The following is a description of a gene set: studied in species Mus musculus Radiotherapy is widely used to treat human cancer. Patients locally recurring after radiotherapy, however, have increased risk of metastatic progression and poor prognosis. The clinical management of postradiation recurrences remains an unresolved issue. Tumors growing in preirradiated tissues have an increased fraction of hypoxic cells and are more metastatic, a condition known as tumor bed effect. The transcription factor hypoxia inducible factor (HIF)-1 promotes invasion and metastasis of hypoxic tumors, but its role in the tumor bed effect has not been reported. Here, we show that tumor cells derived from SCCVII and HCT116 tumors growing in a preirradiated bed, or selected in vitro through repeated cycles of severe hypoxia, retain invasive and metastatic capacities when returned to normoxia. HIF activity, although facilitating metastatic spreading of tumors growing in a preirradiated bed, is not essential. Through gene expression profiling and gain- and loss-of-function experiments, we identified the matricellular protein CYR61 and alphaVbeta5 integrin as proteins cooperating to mediate these effects. The anti-alphaV integrin monoclonal antibody 17E6 and the small molecular alphaVbeta3/alphaVbeta5 integrin inhibitor EMD121974 suppressed invasion and metastasis induced by CYR61 and attenuated metastasis of tumors growing within a preirradiated field. These results represent a conceptual advance to the understanding of the tumor bed effect and identify CYR61 and alphaVbeta5 integrin as proteins that cooperate to mediate metastasis. They also identify alphaV integrin inhibition as a potential therapeutic approach for preventing metastasis in patients at risk for postradiation recurrences. Human Gene Set: MONNIER_POSTRADIATION_TUMOR_ESCAPE_DN from publication Monnier Y, Farmer P, Bieler G, Imaizumi N, Sengstag T, Alghisi GC, Stehle JC, Ciarloni L, Andrejevic-Blant S, Moeckli R, Mirimanoff RO, Goodman SL, Delorenzi M, Rüegg C (PMID 18794119) The postradiation tumor escape signature: genes down-regulated in tumors from irradiated stroma vs those from non-irradiated stroma., and this is the list of marker genes: PTRH2, BNIP3, TMEM238, CCNG2, PDE6D, COL6A3, RABGAP1L, GRHPR, ARHGAP12, PKP2, ADCY7, PIM3, KANSL1L, STAT1, CNIH2, AMOT, CDC42EP3, SRSF5, GMPPA, TRIM21, KMT2C, CLIC1, AKT3, HLTF, TARS3, CAT, APLN, PURA, WDPCP, DCBLD1, MOSPD2, S100A16, EGR1, NFKBIZ, WDR11, DSEL, ZNF729, TGM2, HEBP1, TAPBP, CKLF, IFI16, NCOA2, TENT5A, GJB3, GSTP1, TMEM263, CNOT6L, KIAA2013, MYL6, PRNP (prion protein (Kanno blood group)), TMCC3 (transmembrane and coiled-coil domain family 3), MTERF1, IDH1, ABHD13, TBC1D8B, SEPTIN4, FAM9A, ERRFI1, RBPJ, SHOX2, ZCCHC13, COL5A2, FAR1, CP, CEP41, IER2, HACL1, ABHD14A, PCGF5, TMTC4 (NCBI Gene Id 94896), NDUFB3, WIPI1 (WD repeat domain, phosphoinositide interacting 1), MYCBP2, LGALSL, CEP70, XBP1, NR1D2, S100A1, PLAC8 (NCBI Gene Id 95621), CHID1, DENND5B, TSC22D3, SPOPL, ARL3, STX7, THOC7, MIX23, PNPLA8, CLU, WNT9A, VAPB, SNORD27, PDIA4, FBLIM1, HMGB2, TMSB4X, ARID5B, TTC13, UBE2A, MFGE8, ZFAND2B, CCDC90B, WFDC2, UROS, METTL4, ENPP1, MZT1, ORMDL2, SGK2, PRELID2, GADD45G, MIIP, RASA4B, MXD3, STK17B, RHOB, CPT1A, NUP98, CRIP1, RBL1, RNF217, CASP8, FOS, UGP2, STIM2, STEAP2 (STEAP2 metalloreductase), MARCKS (NCBI Gene Id 4082), CLYBL, RANBP6, SMIM10L1, PPP1R35, TCIM, SSBP3, GGTA1, IMMP2L, PIM1, NDUFAF3, TJP1, C6orf120, HOXA1, PSTPIP1, NAIP, PCBD2, C2orf76, ACSS2, POPDC3, RCOR3, ACAT1, RAPGEF3, LDAF1, TMEM205, TRIM5, SULF2, BCL2L11, TOR1AIP2, OGN, ARHGAP29, FAM111A, RFXANK, BNIP3L, HNRNPA3, RAB9A, NSMCE1, CEP15, PBXIP1, MUS81, H1-0, PPIC, FSTL1, COMMD6, IPP, RBM43 (NCBI Gene Id 389054), SGK1, ZNF438, PLAAT3, KAT8, GCNT2, PLEKHF1, CCDC162P, ABHD8, ZIC5, BLVRA, IDI1, EBP, EEF2K, C5orf24, IZUMO4, SKIL, COL6A1, DECR1, PIGBOS1, SPIDR (NCBI Gene Id 23514), CEP162, OAF, CDK10, KIAA0040, CTSO, IFI30, PNKP, NCK2, UBE2T, HEXB, BUB1, DNPEP, PRKRA, C16orf54, DUSP6, DNAJC3, C12orf57, ANP32A, HPF1, MORN2, E2F7, SMAD7, TTC21B, C15orf48, MIR4435-2HG, LRR1, RRAS, ARTN, RDM1, NDFIP2, PLA2G7, ZRANB3, GSTO2 (glutathione S-transferase omega 2), APOOL, PLAC1, COG4, SNX14, HJURP, LOXL2, FLT3LG, MSLN, DBP, ANKRD37, MGST3, CASD1, CHMP1B2P, CCN2, SPIN4, PLEKHF2, FZD2, UBALD2, CEP57L1, BCL2, APIP, EGLN3, ITGB5, FLOT1, HTATIP2, PPP3CB, PRKAG2, FBXO6, CRYZL1, AK4, ENPP3, LRRC17, FEM1C, PLAC9, RHOBTB1, ACSL3, PPP1R15A, HIKESHI, CDK13, SERTAD1, CHML, SNX24, TSPAN17, AK3, KLF10, PDE5A, ERMARD, MINDY2, OLFML3, IMMP1L, GBP2, HSCB, RND3, LEPROT (leptin receptor overlapping transcript), METTL15, IL12A, SERTAD4, CLDN9, CCN1, ZC2HC1A, KRT18, SLC66A3, LPIN1, ANK1, IFT25, SEPSECS, PDIA6, TMEM37, MUTYH, HPCAL1, SKAP2, GJB5, GPR19, NRARP, TSPO, SGO1, TM7SF2, FGF19, SPATA6, KLF9, RPL15, PDGFA, TSPYL1, FRK, NAE1, SEC62, PHYHD1, ATRAID, RIPOR3 (RIPOR family member 3), PLTP, CYBRD1, NOL3, CRYZ, ENDOU, RMDN1, SOS2, JUN (NCBI Gene Id 3725), COX7B2, ID1, PDK1, ISG20, DYNLT3, KXD1, GRN, TMEM230, FBXL3, ZDHHC2, ARHGAP9, AOX1, VWA5A, UBC, CAST (calpastatin), PDE7A, GGH, CLN5, ZFAND6, CTDSP2, ZNF484, DIPK1A, GSN, NIT1, HOXA5, SIL1 (NCBI Gene Id 64374), NDUFA13, LRRC51, ST6GAL1, GLT8D1, VMA21, SHLD3, SMIM29 (small integral membrane protein 29), UNC93B1, PFKL, ACKR3 (NCBI Gene Id 57007), CCDC38, AMDHD2, CEP72 (NCBI Gene Id 55722), TMCO6, PIAS1, SPICE1, KRCC1, RNF19A, KLF3, EPB41L2, KLF6, IRAK2, ZBTB10, SCRN1, CASP12, BHLHE40, TRAPPC6A, COASY, LSS, COX6A1, HIGD1A, NAXD, COQ3, DMAC2L, COX20, PLD1